The following is a description of a gene set: Any process that stops, prevents, or reduces the frequency, rate, or extent of immunoglobulin production. species: Homo sapiens Human Gene Set: GOBP_NEGATIVE_REGULATION_OF_IMMUNOGLOBULIN_PRODUCTION, and this is the list of marker genes: CR1, IL13RA2, ZPBP2, FCGR2B, NDFIP1, IL33, BCL6 (NCBI Gene Id 604), PARP3, CD22, FOXP3, FCRL3, TMBIM6